The following is a description of a gene set: Genes down-regulated in comparison of untreated macrophages versus those cultured with M-CSF and IFNG. Gene expression analysis of freshly isolated CD14+ human monocytes and monocytes cultured in the presence or absence of interferon (IFN) -gamma for 24 h and then stimulated with Pam3Cys, a Toll-like receptor (TLR) 2 ligand, for 6 h. Results provide insight into mechanisms by which IFN-gamma reprograms early macrophage differentiation and subsequent response to TLR ligands. species: Homo sapiens from publication Hu X, Chung AY, Wu I, Foldi J, Chen J, Ji JD, Tateya T, Kang YJ, Han J, Gessler M, Kageyama R, Ivashkiv LB (PMID 18976936) Human Gene Set: GSE11864_UNTREATED_VS_CSF1_IFNG_IN_MAC_DN, and this is the list of marker genes: PDZD11, BHLHE40, MDFIC, TTTY5, RPE, LONP1, AIFM1, CTTNBP2NL, TIMMDC1, TXLNA, ISG20 (interferon stimulated exonuclease gene 20), NDUFC2, RHOU, FAM200C (family with sequence similarity 200 member C), EDEM1, LINC01010, ATP1B3, WDR76, SIL1, VAC14-AS1, CPSF2, IPO9, PALB2, MCOLN2, ATG3, ZNRF2, XIAP, ZC3H12C, MOB3C, CSTF3, MIR503HG, RIN2, GLA, TXNDC9, CFB, SLC15A4, SNF8, SEPHS2, PLA2G4A, CD81, HSPA6, TTC27, COMMD5, PTPA, C19orf12, ZNF671 (zinc finger protein 671), PTH, DDC-AS1, ANKRD54, PARP9, PMM2, PLRG1, SZT2 (SZT2 subunit of KICSTOR complex), PGBD2, ZNF222, WDR5B, NOL3, NUDCD2, EIF2AK3, SSBP1, TREM2, NSF, ZNF14, RBM28, APTX, UBE2K, ZNF274, EOLA1, PI4K2A, SERPINE2, CTSL, CTNNBL1, YARS1, RAB7A, RGS10, NCOR1, HSPA2, ISX, STARD13, YIPF4, MSANTD4, ZNF19, SDS, DBI, TEC, GIT2, ALOXE3, SLC2A13, EXOSC2, SMCR8 (SMCR8-C9orf72 complex subunit), STX7, MB21D2, NTPCR, MRPS31, COX10, ARL2, DHX16, MAT2B, MLF1, TJP2, PSMC3, CKAP5, LMAN2, TMEM165, LILRB4, UFSP1, CRELD2, SRP68, SEC61G, PDE7A, C11orf54, EARS2, PHTF1, ACACA, CRYBG1, SELENOI, PLOD3, CCDC77, NSMCE4A, MRFAP1L1, ENSG00000290598, CREB3 (NCBI Gene Id 10488), LYSMD2, SMARCAD1, CTSLP8, SLFN11, DDX1, IL6ST, CCT3, DUSP11, GATB, DLAT, USP10, SLC46A3, ZNF112, GTF2IRD1, CDK2AP2, C15orf40 (chromosome 15 open reading frame 40), IMMT, MTHFD1L, ARR3, LNP1, ANKRD27, ZMYND19, FAM20C, ELOC, TARDBP, RNF14, ACTL6A, ZFYVE16, CACYBP, SCO1, MAEA, DAXX, PMVK, LRRC37A2, DCAF1, SIAH1, KCNE5, ATF5, BTN3A3, SMIM29, ZNF234, ADAMDEC1, USP19, KCTD5, LGALS3BP, MOV10, TEX14, DHRSX, TRAM1 (translocation associated membrane protein 1), IFI44L, DTX3L, ARNT2, CNOT4, PSMB3, CHCHD1, SLC30A6, ITGA10, ZNF146, ALDH1A3, POLR2H, PSMD3, ATP6V1G1, NFX1, REEP5, TNPO1, COX7B, DPAGT1 (dolichyl-phosphate N-acetylglucosaminephosphotransferase 1), GOSR1, NUP62, LYSMD3, STX3, HLA-DQB1, NIM1K, SQSTM1, MCEE, OXNAD1, CCM2, UBE2F